Given this list of marker genes Nkiras1, Nfkbib, Nfkb2, Myd88, Ikbkb, Rela, Nfkb1 (nuclear factor of kappa light polypeptide gene enhancer in B cells 1, p105), Nkiras2, Dhx9, Ikbkg, Chuk, Nfkbia, Irf3, here is a description of the gene set: species: Mus musculus ZBP1(DAI) mediated induction of type I IFNs Mouse Gene Set: REACTOME_ZBP1_DAI_MEDIATED_INDUCTION_OF_TYPE_I_IFNS